The following is a description of a gene set: Transcription factor complex which interacts with E-box regulatory elements in target genes, including Period (Per1, Per2, Per3) and Cryptochrome (Cry1, Cry2), to activate their transcription during the daytime. The CRY-PER complexes inhibit CLOCK-BMAL1-driven transcription in a negative feedback loop to generate circadian rhythms. studied in species Homo sapiens Human Gene Set: GOCC_CLOCK_BMAL_TRANSCRIPTION_COMPLEX, and this is the list of marker genes: BMAL1, BMAL2, PASD1, CLOCK, NPAS2